The following is a description of a gene set: The mammalian canonical BRG1-associated factors (BAF) complex is the paralog of the budding yeast SWI/SNF complex. cBAF is smaller and more abundant than the related polybromo-associated BAF (pBAF) complex. Shared between the two complexes are proteins (or members of protein families) that make up the core of both complexes, including SMARCC and SMARCD proteins, the catalytic subunits SMARCA4 (BRG1) or SMARCA2 (BRM), ACTB, ACTL6A/B and BCL7A/B/C (Wang, Cote et al, 1996; Wang, Xue et al, 1996; Mashtalir et al, 2018; Mashtalir et al, 2020; He et al, 2020; reviewed in Mittal and Robert2, 2020; Cenik and Shilatifard, 2021; Wang and Tang, 2023). Distinguishing components of the cBAF complex include ARID1A or ARID1B, and DPF1/2/3, and SS18 or SS18L1 (shared with ncBAF, described below).<br>Mammalian cBAF complexes are required for chromatin remodelling and oppose polycomb repression. Unlike in yeast, however, mammalian cBAF complexes are able to support both gene activation and repression. species: Homo sapiens Reactome Pathway: Formation of the canonical BAF (cBAF) complex part of: SWI/SNF chromatin remodelers, and this is the list of marker genes: SMARCA4, BCL7B, ARID1A (NCBI Gene Id 8289), SMARCA2, SMARCD1, SMARCE1, SMARCC1, DPF1, ACTB, DPF2, SS18, ACTL6A, DPF3, SS18L1, BCL7A, BCL7C, ARID1B, SMARCB1